Given this list of marker genes CST3, EGLN1, CTSF, TINAGL1, ANGPTL4 (angiopoietin like 4), EFEMP2, CCN2, HTRA1, LTBP3, ADAM9, TIMP1, AGRN, COL24A1, P4HTM, P3H3, ADAM10, SNED1, COL22A1, LOXL2, CTSB, S100A10, PRG4, SRPX, CTSC, S100A2, IGFBP4, HCFC2, SERPINE2, MFGE8, here is a description of the gene set: Human Gene Set: NABA_MATRISOME_HIGHLY_METASTATIC_BREAST_CANCER_TUMOR_CELL_DERIVED studied in species Homo sapiens from publication Naba A, Clauser KR, Lamar JM, Carr SA, Hynes RO (PMID 24618895) To define the ECM composition of tissues and tumors, we have empolyed a proteomics-based method to enrich and identify ECM proteins and coupled it with a bioinformatic annotation of the matrisome defined as the ensemble of ECM and ECM-associated proteins. To identify ECM proteins important for breast cancer progression and metastasis formation, we used a xenograft model where human breast cancer cells of differing metastatic potenital were orthotopically injected into the mouse mammary fat pad. The poorly metastatic MDA-MB-231 cell line was established from cells isolated from a sample from a triple-negative breast cancer patient. The highly metastatic MDA-MB-231-LM2 line (denoted LM2), was previously selected and characterized for increased metastatic potential to the lungs. 6.5 weeks post-injection, the primary tumors were harvested, ECM proteins were enriched from tumors, and the composition of the ECM-enriched fractions obtained was characterized by mass spectrometry. We define the matrisome of a tumor as the ensemble of proteins detected in two independent biological replicates and by at least two peptides in one of the two replicates. Using this proteomics approach we show that both the tumor cells and the stromal cells contribute in characteristic ways to the production of the tumor ECM. Moreover, we show that both tumor- and stroma-derived proteins differ between tumors of different metastatic potential. Comparison of the matrisomes of MDA-MB-231 tumors and LM2 tumors identifies ECM proteins characteristic of poorly and highly metastatic tumors. This gene set lists the matrisome proteins secreted by the tumor cells in LM2 tumors and not from MDA-MB-231 tumors. Tumor-cell-derived matrisome proteins exclusively detected in highly metastatic breast cancer human-to-mouse xenografts (MDA-MB-231_LM2) in comparison to poorly metastatic breast cancer human-to-mouse xenografts (MDA-MB-231).